The following is a description of a gene set: species: Mus musculus Any process that results in a change in state or activity of a cell (in terms of movement, secretion, enzyme production, gene expression, etc.) as a result of an exogenous double-stranded RNA stimulus. Mouse Gene Set: GOBP_CELLULAR_RESPONSE_TO_EXOGENOUS_DSRNA, and this is the list of marker genes: Mul1, Zcchc3, Tlr3, Cgas, Dhx9, Ifih1, Ciita, Flot1, Zc3hav1, Sting1, Raet1d, Pqbp1, Mavs, Cav1, Rigi, Ralb, Colec12